Given this list of marker genes H2-K1, H2-T22, H2-Q4, H2-T23, H2-Q7, H2-M1, H2-M10.4, H2-M11, H2-M10.1, H2-Q10, H2-D1, H2-Q2, H2-M5, Fcgrt, H2-M10.2, H2-M10.5, H2-M2, H2-Q1, H2-M10.6, Hfe, H2-T3, H2-T10, Mr1, H2-M10.3 (NCBI Gene Id 386452), H2-Q6, H2-M9, here is a description of the gene set: Binding to beta-2-microglobulin. species: Mus musculus Mouse Gene Set: GOMF_BETA_2_MICROGLOBULIN_BINDING